Given this list of marker genes TPM2, THBS2, COL6A3 (collagen type VI alpha 3 chain), IER2, SULF1, SFTPB, IER3, SERPINE1, NR4A2, CXCL2, TGFBI, OLFM1, CCN2, FSCN1, IGFBP7, FOSB, GABBR2, ACTA2, VCAN, TSC22D3, SPTBN1, LOX, MICAL2, CXCL1, DUSP1, GABRA5, ID1, H2AC18, RPS4Y1, IL6, COL1A2, COL6A1, BASP1, RGS2, NUPR1 (nuclear protein 1, transcriptional regulator), PPP1R15A, IGFBP3, IGHV5-78, SMARCD3, CXCL3, NFKBIA, CCL4, PIM2, LUM, TMSB4X, NNMT (nicotinamide N-methyltransferase), TGM2, NOTCH3, FOS, CCL3, SLC25A4, GUCY1A2, IGFBP4, SPARC, MYOF, LAMA4, here is a description of the gene set: Human Gene Set: CROONQUIST_STROMAL_STIMULATION_UP species: Homo sapiens from publication Croonquist PA, Linden MA, Zhao F, Van Ness BG (PMID 12791645) Genes up-regulated in ANBL-6 cell line (multiple myeloma, MM) co-cultured with bone marrow stromal cells compared to those grown in the presence of IL6. ANBL-6, a myeloma cell line, proliferates in response to interleukin 6 (IL-6) stimulation, coculture with bone marrow stromal cells, and when harboring a constitutively active mutant N-ras gene. Eighteen samples, including 4 IL-6-treated, 3 mutant N-ras-transfected, 3 normal stroma-stimulated, 2 multiple myeloma (MM) stroma-stimulated, and 6 untreated controls were profiled using microarrays interrogating genes. Global hierarchical clustering analysis distinguished at least 6 unique expression signatures. Notably, the different stimuli altered distinct functional gene programs. Class comparison analysis (P =.001) revealed genes (54% involved in cell cycle) that distinguished IL-6-stimulated versus nontreated samples. Eighty-seven genes distinguished stroma-stimulated versus IL-6-treated samples (22% encoded for extracellular matrix proteins). A total of genes distinguished N-ras transfectants versus IL-6-treated samples (26% involved in metabolism). A total of genes, 20% of these involved in signaling, distinguished N-ras from stroma-interacting samples. All 3 stimuli shared genes, mostly of metabolic function. Genes that distinguished MM1 from MM4 clinical groups were induced at least by one treatment. Notably, only genes (ETV5, DUSP6, and KIAA0735) are uniquely induced in mutant ras-containing cells. We have demonstrated gene expression patterns in myeloma cells that distinguish an intrinsic genetic transformation event and patterns derived from both soluble factors and cell contacts in the bone marrow microenvironment.